The following is a description of a gene set: Human Gene Set: GOBP_NEGATIVE_REGULATION_OF_CALCIUM_ION_TRANSMEMBRANE_TRANSPORT Any process that stops, prevents or reduces the frequency, rate or extent of calcium ion transmembrane transport. studied in species Homo sapiens, and this is the list of marker genes: UBQLN1, GSTO1, REM1, CRHR1 (corticotropin releasing hormone receptor 1), CBARP, UCP2, SLN, PPP3R1, MCUB, FMR1, VDAC1, MIR328, EPO (NCBI Gene Id 82670), YWHAE, PPP3R2, CALM3, GNB5 (G protein subunit beta 5), PPP3CA, UBR3, CACNA1F, MIR1-1, BCL2, MIR499A, CALCA, MIR208A, PPP3CC, CALM2, PLN, TMBIM6, TLR9, TGFB1, MIR208B, CALM1 (NCBI Gene Id 801), ATP1A2, SESTD1, BIN1, MIR200C, GPR35, PPP3CB, NTSR1, NOS1, FKBP1B